The following is a description of a gene set: Human Gene Set: HP_APLASIA_HYPOPLASIA_OF_THE_4TH_FINGER A small/hypoplastic or absent/aplastic 4th (ring) finger. Aplasia/Hypoplasia of the 4th finger studied in species Homo sapiens, and this is the list of marker genes: GDF5, MECOM, NOG, COL2A1, TBX3